The following is a description of a gene set: Any process that modulates the frequency, rate, or extent of natural killer cell mediated immunity. Human Gene Set: GOBP_REGULATION_OF_NATURAL_KILLER_CELL_MEDIATED_IMMUNITY studied in species Homo sapiens, and this is the list of marker genes: GRB2, NCR3, KLRC4, CRK, CALHM6, SERPINB9, KLRD1 (NCBI Gene Id 92677), SERPINB4, CRTAM, HLA-G, KIR2DL4, ARRB2, NECTIN2, LGALS9, CADM1, KLRK1, RASGRP1, RAET1G, HAVCR2, LEP, RASGRP4, SH2D1A, NECTIN4, NCR1, LAMP1, KLRC3, IL18RAP, KLRC2, HLA-A, STAT5B, INPP5D, HLA-E, AP1G1, PIK3R6, IL12B, LAG3, SH2D1B, CLEC12B, CD160, IL21, PVR, VAV1, RAET1E, IL12A, MICA, TIGIT, KLRC1, STAT5A, CD226, CD96, KLRB1, TGFB1, HLA-F, HLA-B, LILRB1, SLAMF6, CEACAM1, KLRC4-KLRK1, CLNK